The following is a description of a gene set: part of: Acetylcholine binding and downstream events Reactome Pathway: Presynaptic nicotinic acetylcholine receptors species: Homo sapiens Presynaptic acetylcholine receptors are located at or near nerve terminal and modulate the release of neurotransmitter such as glutamate, noradrenaline and dopamine. Activation of presynaptic acetylcholine receptors leads to influx of Ca2+ and sufficient increase in local Ca2+ concentrations which could be due to either direct or indirect Ca2+ entry. Direct Ca2+ entry through acetylcholine receptors containing alpha3 beta4 receptors is sufficient for the release of noradrenaline in hippocampus. Indirect Ca2+ increase could be due to Na+ dependent depolarization and activation of voltage dependent calcium channels (VDCC) as in the case of dopamine release. Local Ca2+ increase could also be due to an initial Ca2+ influx through acetlycholine homomeric receptors containing alpha7 subunits and further increase in Ca2+ is elicited due to Ca2+ induced Ca2+ release (CICR) that involves the ryanodine receptors in the ER and the IP3 receptors. This mechanism is used in hippocampal mossy fibre pathway. Nicotinic acetylcholine receptors may permit both sodium and calcium ions, however, the ratio of sodium and calcium influx makes these receptors either highly sodium permeable or highly calcium permeable., and this is the list of marker genes: CHRNB2, CHRNA2, CHRNA5, CHRND, CHRNA1, CHRNE, CHRNG, CHRNA3, CHRNA4, CHRNB3, CHRNA6, CHRNB4